Given this list of marker genes Rdx, Tacstd2, Eps8l2, Stap1, Eps8, Evl, Wdpcp, Ccl21f, Pfn2, Pip5k1a, Inpp5k, Pdgfrb, Lima1, Sh3yl1, Eps8l3, Plekhm1, Ccl21a, Plek, Ccl21e, Hras (NCBI Gene Id 15461), Fam98a, Wdr72, Arhgap24, Plekha1, Ndel1, Arhgef26, Tpm1, Eps8l1, Cspg4, Aif1, Cyfip1, P2ry12, Cobl, Lpin1, Ccl21b, Ccl21d, Coro1b, Bag4, Coro1c, Sh3bp1, Ston1, Usp17le, Carmil1, Mtor, Aif1l, Nlgn1, Rcc2, Csf1r, Snx10 (NCBI Gene Id 71982), Kank1, Inppl1, Cav1, Icam1, Rhog, Arf6, Rac1, Def8, Tcirg1, Carmil2, Pfn1, here is a description of the gene set: species: Mus musculus Mouse Gene Set: GOBP_RUFFLE_ORGANIZATION A process that is carried out at the cellular level which results in the assembly, arrangement of constituent parts, or disassembly of a ruffle, a projection at the leading edge of a crawling cell.